The following is a description of a gene set: The expansion of an alpha-beta T cell population by cell division. Mouse Gene Set: GOBP_ALPHA_BETA_T_CELL_PROLIFERATION species: Mus musculus, and this is the list of marker genes: Cd24a, Tnfsf4, Syk, Ptpn22, Dock2, Cd81, Cd3e, Elf4, Tnfsf18, Ripk2, Twsg1, Tnfrsf14, Tyk2, Cd44, Myc, Cd244a, Il15, Rasal3, Il2, Card11, Xcl1, Lilrb4a, Lgals9, Mapk8ip1, Sh3rf1, Arg2, Prkcq, H2-T23, Tgfbr2, Irgm1, Cd28, Tarm1 (T cell-interacting, activating receptor on myeloid cells 1), Foxp3, Cd80, Itch, Jak2, Il2ra, Il12b, Clec4g, Cd55b, Ndfip1, Cd55, Irf1, Zbtb7b (zinc finger and BTB domain containing 7B), Zap70, Blm (NCBI Gene Id 12144), Ccr2, Cblb, Ptprc, Vsir, Btla, Il23a, Il18, Cd274, Slc4a2